Given this list of marker genes Il6st, Clcf1, Nr2e1, Cntn2, Nr1d1, Nf1, Epha4, Shh, Lif (NCBI Gene Id 16878), Bmp2, Notch1, Prpf19, Csf1r, Mbd1, Bin1, Atf5, Id2, Mag, Hes5, Qki, Ntrk3, F2, Ldlr, Nog, Mycn, Gpr37l1, Hmga2, Serpine2, Dab1, Actr3, Id4, Kdm4a, Dll3, Fgfr3, Trem2, Hes1 (hes family bHLH transcription factor 1), Il1b, Mecp2, here is a description of the gene set: species: Mus musculus Mouse Gene Set: GOBP_REGULATION_OF_ASTROCYTE_DIFFERENTIATION Any process that modulates the frequency, rate or extent of astrocyte differentiation.